Given this list of marker genes ID2, SPINT1, SERP1, ALDOC, HAVCR1, CYB561, CMAS (cytidine monophosphate N-acetylneuraminic acid synthetase), XBP1, CLDN3, EHF, TFAP2C, GOLPH3, CHMP2B, LSR, ACSL4, IRX3, CD82, LITAF, SHROOM3, FXYD3, ELL2, CLDN7 (NCBI Gene Id 1366), PLET1, WWC1, IRF6, ATP6AP2, ATP6V1A, TPD52, LRRFIP1, SLC66A2, GALNT3, ARHGEF5, SS18L2, CRYBG1, VDR, EBP, KCNN4, DAP, SRP19, RNF149, RETREG1, NUCB2, DSG2, SOX4, LCN2, STRBP, here is a description of the gene set: Human Gene Set: LANDIS_BREAST_CANCER_PROGRESSION_UP species: Mus musculus Genes up-regulated in preneoplastic mammary tissues and whose expression is maintained in tumors. Epidemiological studies indicate that parity enhances HER2/ErbB2/Neu-induced breast tumorigenesis. Furthermore, recent studies using multiparous, ErbB2/Neu-overexpressing mouse mammary tumor virus (MMTV-Neu) mice have shown that parity induces a population of cells that are targeted for ErbB2/Neu-induced transformation. Although parity accelerates mammary tumorigenesis, the pattern of tumor development in multiparous MMTV-Neu mice remains stochastic, suggesting that additional events are required for ErbB2/Neu to cause mammary tumors. Whether such events are genetic in nature or reflective of the dynamic hormonal control of the gland that occurs with pregnancy remains unclear. We postulated that young age at pregnancy initiation or chronic trophic maintenance of mammary epithelial cells might provide a cellular environment that significantly increases susceptibility to ErbB2/Neu-induced tumorigenesis. MMTV-Neu mice that were maintained pregnant or lactating beginning at 3 weeks of age demonstrated accelerated tumorigenesis, but this process was still stochastic, indicating that early pregnancy does not provide the requisite events of tumorigenesis. However, bitransgenic mice that were generated by breeding MMTV-Neu mice with a luteinizing hormone-overexpressing mouse model of ovarian hyperstimulation developed multifocal mammary tumors in an accelerated, synchronous manner compared to virgin MMTV-Neu animals. This synchrony of tumor development in the bitransgenic mice suggests that trophic maintenance of the mammary gland provides the additional events required for tumor formation and maintains the population of cells that are targeted by ErbB2/Neu for transformation. Both the synchrony of tumor appearance and the ability to characterize a window of commitment by ovariectomy/palpation studies permitted microarray analysis to evaluate changes in gene expression over a defined timeline that spans the progression from normal to preneoplastic mammary tissue. These approaches led to identification of several candidate genes whose expression changes in the mammary gland with commitment to ErbB2/Neu-induced tumorigenesis, suggesting that they may either be regulated by ErbB2/Neu and/or contribute to tumor formation. from publication Landis MD, Seachrist DD, Abdul-Karim FW, Keri RA (PMID 16434967)